The following is a description of a gene set: studied in species Mus musculus Mouse Gene Set: GOMF_K48_LINKED_DEUBIQUITINASE_ACTIVITY Hydrolysis of a ubiquitin unit from a ubiquitinated protein linked via the Lys48 residue of ubiquitin., and this is the list of marker genes: Mindy2, Usp8, Otud7b, Usp26, Usp36, Usp27x, Usp13, Yod1, Desi2, Mindy4b-ps, Usp19, Mindy3, Mindy1, Mindy4, Atxn3 (ataxin 3), Usp7, Usp9x, Usp15, Cyld, Cep63, Otud5